Given this list of marker genes Tnfrsf13c, Rc3h1, Ada, Tnfaip3, Mef2c, Foxj1, Tnfsf13b, H2-DMa, Pkn1, Tnfsf13, here is a description of the gene set: Mouse Gene Set: GOBP_REGULATION_OF_GERMINAL_CENTER_FORMATION studied in species Mus musculus Any process that modulates the frequency, rate, or extent of germinal center formation.